Given this list of marker genes VWF, COL1A2, ADAMTS13, COL1A1, here is a description of the gene set: part of: Defects of platelet adhesion to exposed collagen species: Homo sapiens Reactome Pathway: Enhanced cleavage of VWF variant by ADAMTS13 Under normal physiological conditions, a disintegrin and metalloproteinase with thrombospondin type 1 repeats 13 (ADAMTS13) downregulates von Willebrand factor (VWF) procoagulant activity by cleaving the peptide bond between Tyr1605 and Met1606 of VWF in a shear-dependent manner.